Given this list of marker genes Grap, Cdk4, Emb, Grn, Rsrp1, Itgax, Slc31a2, Nfic, Zfp36l2, Gngt2 (guanine nucleotide binding protein (G protein), gamma transducing activity polypeptide 2), Fosb, Cybb, Stard9, Il6st (NCBI Gene Id 71317), Ccpg1, Nsmaf, Mink1, Atp8a1, Lrrk2, Eef2, Gpsm3, Kdm7a, Lyz2, Clec4b1, Pot1b, Sms, Tlr2, Hsd17b11, Stap1, Cd180, Arrb1, Ank, Tns3, H2-K1, Macf1, Ypel3, Chka, Dock4, H2-T23, Plekha2, Tnfaip8l2 (NCBI Gene Id 99931), Ms4a6c, Neurl3, Anxa1, Iqgap2, H2az1, Pip4k2a, Mrpl30, Spn, Rpn2, Ehd4, Ptma, Tpd52, Arhgap17, Rgs18, H2-Ab1, Fam107b, Slc6a6, Itm2b (NCBI Gene Id 214227), Mcm7, Septin3, Eif4ebp2 (NCBI Gene Id 69229, eukaryotic translation initiation factor 4E binding protein 2), Sorl1, Pip4p1, Aldoa, Shtn1, Itpr1, Plbd1, Bmt2, Ptpn6, Ccrl2, Rp2, Snx10, Asnsd1 (asparagine synthetase domain containing 1), Cdk14, Ctsa, Smad7, Arhgef6 (NCBI Gene Id 76697), Notch2, Sdc3, Ttc3, Chil5, Bst2, Camk1d, Dnmt3a, Marveld1, Sp100, Fxyd5, Calhm6, Apbb1ip, Slc2a3, Zfp36, Slc38a1, Pttg1, Dynlt2b, Epcam, Arpc5l, Ubash3b, Hk2 (hexokinase 2), Rgs3, Deptor, Bin1, Ppfia4, Srpk2, Mob3b, Stard5, Mideas, Hpgd, Alox5ap, Ctsh, Cdc42se2, Pgap1, Eif4b, Ly86, Gm2a, Hspa1a, Clk4, Stmn1, Ier5, Pid1, Lpin2, Pglyrp1, Coro1a, Ptpra, Me2, Add3, Fkbp15, Matk, Sgpp1 (NCBI Gene Id 81535), Rassf5, Bloc1s2, Tkt, Slc46a3, Spib, Idh1, Tsc22d4, Inpp5d, Sod1, Camkk2, Asah1, St8sia1, Macroh2a1, Tet3, Ptp4a3, Ifnar2, Limd2, E2f2, Lst1, Txnip, Cd68, Carmil1, Tyk2, Lztfl1, Arl5c, Ptprs, Npc2, Gltp, H2-T22, Ppt2, Tia1, Arhgap45, Ccl9, Il16, Apobr, Abca1, Rnf166, Nfatc2, Skint3, G6pdx, Colgalt1, Ccr9, Cd37, Ifitm6, Il17ra, Akr7a5, Plekho1, Gpr141, Lpin1 (lipin 1), Egr1, Slc48a1, Alcam, Mpeg1, Aldh2, Gng2, Epsti1, Dnase2a, Mindy2, Sec11c, Arid1a, Ifngr1, Sulf2, Ccr2, AB124611, Abhd17a, Arhgap5, Pold4, Cyb5a, Mrpl28, Ckap4, Slc29a3, Celf2, Sirpa, Psap, Vamp5, Reep5, Arhgap15, Taldo1, Mapk14, Rnf130, Bcl11a, Zeb2, Bin2, Acaa2, Prr5l, St8sia6, Abi3, Stx16 (syntaxin 16), Wdfy2, Clec12a, Ivns1abp, Creg1, Mbnl1, Zmiz1, Nup210, Ptpn18, Fbrsl1, Pmaip1, Shisa5, Ramp1, Plac8, Dpy19l1, Klf13, Scp2, Tifab (TRAF-interacting protein with forkhead-associated domain, family member B), Pepd, Slc12a6, H2-DMa, Sh3kbp1, Plekhm3, Rcsd1, Kxd1, Tbc1d9, Clec4a3, Ifi203, Calhm2, Parp8, Nav1, Abca7, Tnni2, Mdp1, Arsb, Mxd4 (NCBI Gene Id 69247), Ckb, Sema4d, Ctsd, Foxp1, Rasgrp2, Cd7, Prkacb, Psme2b, Slc66a2, Rbfa, Ccdc50, Bnip3l, Herc1, L1cam, Rgs10, Lgals3, Gpi1, BC035044, Lmo4, Rnase6, Nfkbiz, Plxnb2, Med30, Tep1, Atp5if1, Mef2a, Anp32a, Top2b, Tnrc6b, Bri3bp, Unc119, Hexb, Arhgap25, Glipr1, Smpdl3a, Raph1 (Ras association (RalGDS/AF-6) and pleckstrin homology domains 1), Nr4a1, Uggt1 (UDP-glucose glycoprotein glucosyltransferase 1), Nedd4, Zfp710, Igsf6, Clec4a2 (NCBI Gene Id 26888), Cotl1, Gsn, Stk10, Mrpl33, Sipa1, Fuca2, Fos, Polr2g, Plekhg3, Ndufa6, Susd3, Ms4a6b, Casp1, Asap1, Plxnc1, Pals2, Lrrc25, Ddrgk1, Cd4 (NCBI Gene Id 212762), Pld4, Tmco1, Micu1, Klhl24, Tmsb10, Higd2a, Lbh, Mvb12a (multivesicular body subunit 12A), Ptprc, Plxdc1, Slamf8, Khk, Hmgb1, Ubac2, Ctsb, Cd47, Gnai2, Plxnd1, Ctss, Ubc, Otulinl, Sh3bgrl3, H2-Aa, Lyl1, Lmo1, H1f2, Vrk2, Ier2, Tmem50a, Cmtm7, Lasp1, Cnpy3, Ffar4, Ppp3ca, Septin9, Arhgef1, Rassf4, Commd8, Hmgb2, Il13ra1, Atf3, Nadk, Atraid, Specc1, Stom, BC028528, Ppt1, Rfc1, Irgm1, Myo1f, Ctnna1, Gmfg, Erp29, Smim14, Zbtb20, Wasf2, Amz1, Gns, Tle5, Spns3 (NCBI Gene Id 77577), Xpr1, Surf1, Timp2, Ppp1r12c, Stat1, Slc43a2 (solute carrier family 43, member 2), Csk, H2-DMb1, Elmo2, Rgl1, Smc6, Tmcc1, Lemd2, Apobec1, Bmyc, Jup, Anxa6 (annexin A6), Sgpl1, Degs1, Tmem238, Adgre4, Cox20, Nfkbid, Ankrd13a, Smim5, Fgd2, Lrwd1, Fam111a, Cdc42ep3, Dock2, Taok3, Hpse, Zfp652, Nap1l1, Selenoh, Gpr34, Unc93b1, Cd52, Akna, Pstpip1, Mef2c, Clk1 (CDC-like kinase 1), Itgal, Csnk1g3, Itgb7, H2ac24, Rasgrp4 (NCBI Gene Id 233046), Tmed3, Nedd9, Dpp4, Ccl4, Ttc7, Ncoa1, Mia2, Cadm3, Lamtor4, Lat2 (linker for activation of T cells family, member 2), Btla, Tm6sf1, Cd300c2, Sirpb1a, Tbl1xr1, Smarca2, Pnpla7, Nfam1, Dek, Rab32, Nek7, Plcg2, Dhrs1, Celf4, Scarb2, Hck, Ncf2, Hebp1, Uvrag, Trps1, Rasa4, Tent5a, Adss1, Fyb1, Sat1, Rnf13, Ubn1, Hlcs, Ighm, Emc10, Klf2, Aif1, Ptpa, Ccdc88c, Dipk1a, Man2b1, R3hdm4, Lpcat2, Eif3e, Ptms, Rnpep, Dna2, Cbfa2t3 (CBFA2/RUNX1 translocation partner 3), Oxct1, Ltb (lymphotoxin B), 9930111J21Rik2, Marchf1, Cox7a2l, Trappc5, Evi2a, Cyfip2, Arhgdib, Ogt, Prcp, Themis2, Itgb2, Gpx4, Septin11, H2az2, Ptpn22, Mcemp1 (NCBI Gene Id 69189), Stk38, Adgre1, Irag2, Dnajb14, Dguok, Atp6ap1, Arhgap9, Dock10, H2-D1, H2-Oa (histocompatibility 2, O region alpha locus), Fcor, Spata13, Hexa, Hspa1b, Eeig2, B4galt6, Vsir, Tyrobp, Mapk3, Abca9, Stk17b, B2m, Ctsc, Tmem219, Clic1, Wls, Ccnd1, Anxa5, Ncf1, Slc15a4, Ptp4a2, Cx3cr1, Evl, Tmem59, Rhob, Mfsd6, Epb41l2, Tor1aip1, Plekho2, Ptpro, Pak1, Gpx1, Mtpn, H2-Eb1, Aph1c, Btg2, Zfp467, Irf8, Cyp27a1, Klf4, Flt3, Abcg1, Ids, Gdi2, Lyst, Samhd1 (NCBI Gene Id 56045), Lipa, Fes, Cd200r1, Selenop, Fuca1, Atp13a2, BC005537, Atg3, Tor3a, Cd81, Ccl6, Dhrs7, Nr3c1, Myo5a, Cd300lg, Dnajc7, Grcc10, Neat1, Snx18, Lag3, Adipor1, Ssh2, Plcb2, Daglb, Septin6, Bri3, Nceh1, Tifa, Adcy7, Mcub, Jun, Git2, Nfix, Lpxn, Csf1r, Sptssa, Txndc15, Idh2, Trf, Pycard, Ptpre, Rgs2, Hps3, Laptm5, Naga, Cd300ld, Haus8, Pea15a, Clec4a1, Tecr, Ptgs2, Sowahc, Tmpo, Samd9l, Akr1b1, Rnd3, Tubb5 (tubulin, beta 5 class I), Lsp1 (lymphocyte specific 1), Borcs6 (NCBI Gene Id 71923), Nr4a2 (NCBI Gene Id 18227), Tut4, Cib1, here is a description of the gene set: from publication Cui A, Huang T, Li S, Ma A, Pérez JL, Sander C, Keskin DB, Wu CJ, Fraenkel E, Hacohen N (PMID 38057668) Mouse Gene Set: CUI_CDC2_IL1B_RESPONSE_DN Cytokines mediate cell-cell communication in the immune system and represent important therapeutic targets. A myriad of studies have highlighted their central role in immune function, yet we lack a global view of the cellular responses of each immune cell type to each cytokine. To address this gap, the authors created the Immune Dictionary, a compendium of single-cell transcriptomic profiles of more than 17 immune cell types in response to each of 86 cytokines (>1,400 cytokine-cell type combinations) in mouse lymph nodes in vivo. A cytokine-centric view of the dictionary revealed that most cytokines induce highly cell-type-specific responses. For example, the inflammatory cytokine interleukin-1β induces distinct gene programmes in almost every cell type. A cell-type-centric view of the dictionary identified more than 66 cytokine-driven cellular polarization states across immune cell types, including previously uncharacterized states such as an interleukin-18-induced polyfunctional natural killer cell state. Genes negatively differentially expressed in cell type: cDC2 (conventional dendritic cell type 2) upon treatment with cytokine: IL-1β in mouse lymph nodes in vivo. studied in species Mus musculus